Given this list of marker genes YWHAQ, PBX3, UBE2G1, TBC1D23, STK39, NUDT9, INMT, MAPRE2, PDCD6IP, CHRNE, VPS4B, KMT5A, APMAP, NSUN6, GTF2F1, LCP1 (lymphocyte cytosolic protein 1), MACROD1, TSPYL1, ETV4, SEPTIN11, BBLN, CYSLTR2, DNAJC2, PTPN11, LRRC59, MGAT2, PPP2R3C, DACH1, C19orf25, ABCC1, NLGN2, SLC7A2, UTP11, CD247, HMGN5, GABRP, GSTA5, ABCA4, GABPA, GET4, CISH, SH3BGRL2, IER5, TMED7, LSM10, BRIX1, RSRC2, SHC1, HERC2, IMP4, QPCTL, COX6B1, STK17B, ATP2A2, MAF, CLMP (NCBI Gene Id 79827), IER3IP1 (immediate early response 3 interacting protein 1), ARHGAP21, HADHA, OR13J1, RPS5, CCL22, F10, GPR155, DMAC1, EMC7, HINFP, CALCRL, LANCL2, NMNAT1, TNFSF9, GTF2B, RAC2, SUCO (SUN domain containing ossification factor), TMEM39A, EEF2K, GGCX (NCBI Gene Id 2677), BOP1, USP47, C1orf35, DHPS, CRB1, LAMB1, VASP, PRDX5, TNFRSF1B, MPHOSPH6, ATF7IP2, KPNB1, ALCAM, TNFAIP8, TMED5, SYNPO2, CDC25A, C11orf96, ACSL5, C2orf49, CELSR1, CMTR1, RPL24, STRN4 (NCBI Gene Id 29888), GLA, ACLY, PSMA3, TCAF2, CAB39L, WIZ, MOB1B, VPS37C, CAMSAP1, LIMD1, CCL17, OBI1, RRP36, CEP19, KATNBL1, NIBAN2, HJURP, NR1I3, FBXO33, CCL13, EIF4E, SLC6A12, AP3S2, SPRYD4, CS, NDEL1, IL10, PABPC4, FPR2, MOAP1, CKS2, DDX27, UBE2W, RAB20, NMD3, ATXN2, MEP1A, TSHZ1, AOAH, OAT, SFT2D2, IL36A, LRRC8C, PMEPA1, OTUD4, SENP2, COX19, KIF5C, XYLT2, RNF145, TMEM120B, FSTL3, TBPL1, SEC23IP, BOD1L1, FAM133B, TAGLN2, IL1RAP, IGBP1, TMEM11, PPIF, ECM1, CLEC4D, TBC1D15 (TBC1 domain family member 15), NEU2, RWDD1, GNAT1 (NCBI Gene Id 2779), MAK16, MFSD14A, PPP2R1A, PLAAT3, PHTF1, AKT3, ATP5MC3, VCP, SGCB, PURB, ALDH1A2, GADD45B, CCN3, ERCC3, SERINC1, SMIM30, TNFSF4, ZFYVE16, GRK2, EIF3E, STK4 (serine/threonine kinase 4), UQCRHL (NCBI Gene Id 440567), TXNDC5, GABARAP, TRAPPC5, GSR, POGLUT1, TP53RK, ARMCX3, STIP1, CCDC90B, PSMD7, here is a description of the gene set: mouse primary BMDCs were stimulated with tlr ligands and gene expression changes were profiled on Affymetrix arrays Human Gene Set: GSE17721_LPS_VS_POLYIC_6H_BMDC_UP studied in species Homo sapiens from publication Amit I, Garber M, Chevrier N, Leite AP, Donner Y, Eisenhaure T, Guttman M, Grenier JK, Li W, Zuk O, Schubert LA, Birditt B, Shay T, Goren A, Zhang X, Smith Z, Deering R, McDonald RC, Cabili M, Bernstein BE, Rinn JL, Meissner A, Root DE, Hacohen N, Regev A (PMID 19729616) Genes up-regulated in comparison of dendritic cells (DC) stimulated with LPS (TLR4 agonist) at 6 h versus DC cells stimulated with poly(I:C) (TLR3 agonist) at 6 h.